The following is a description of a gene set: species: Homo sapiens Leg shortening because of underdevelopment of one or more bones of the lower extremity. Human Gene Set: HP_LOWER_LIMB_UNDERGROWTH Lower limb undergrowth, and this is the list of marker genes: MMP13, NOG, SLC26A2, ADNP, LAMA5, PAPSS2, EXT1, GNA11, SHOX, COL2A1 (collagen type II alpha 1 chain), CHUK, FN1, ALPL, PPIB, ARL6IP6, EXT2